The following is a description of a gene set: Genes temporally down-regulated by CD44 stimulation of B lymphocytes. from publication Högerkorp CM, Bilke S, Breslin T, Ingvarsson S, Borrebaeck CA (PMID 12411303) studied in species Homo sapiens A number of studies have implicated a role for the cell surface glycoprotein CD44 in several biologic events, such as lymphopoiesis, homing, lymphocyte activation, and apoptosis. We have earlier reported that signaling via CD44 on naive B cells in addition to B-cell receptor (BCR) and CD40 engagement generated a germinal center-like phenotype. To further characterize the global role of CD44 in B differentiation, we examined the expression profile of human B cells cultured in vitro in the presence or absence of CD44 ligation, together with anti-immunoglobulin (anti-Ig) and anti-CD40 antibodies. The data sets derived from DNA microarrays were analyzed using a novel statistical analysis scheme created to retrieve the most likely expression pattern of CD44 ligation. Our results show that genes such as interleukin-6 (IL-6), IL-1alpha, and beta(2)-adrenergic receptor (beta(2)-AR) were specifically up-regulated by CD44 ligation, suggesting a novel role for CD44 in immunoregulation and inflammation. Human Gene Set: HOEGERKORP_CD44_TARGETS_TEMPORAL_DN, and this is the list of marker genes: NR4A3, FXN, HTR1A, APOC3, USP6NL, WASHC5, GCG, LYZ, MNAT1 (NCBI Gene Id 4331), AUH, PIK3R3, PRKACA, EFNA3, MX2, SLC18A1, TERF1, CCNG2, DELE1, CRYGC, PLK1, ELL, MEF2A, PAFAH2, SNCA, NUCB2